Given this list of marker genes H2AC16, KCNJ4, MOB1A, GAS6, CYP3A5, SPRR1B, EPB41L2, IGSF3, ZNF254, STK4, TAF12, MGP, MAGI2, NR4A3, ORC2, PPP1R16B, GNMT, UBTF, RFXAP, NMI, MYH6, C1S, ERICH1 (NCBI Gene Id 441310), CCL18, CPNE1, SOCS1, MYH9, KCTD17, SPINT2, PTPRR, UBB, HLA-DRA, CRH (NCBI Gene Id 1392), TTC39A, UBL3, KNG1, RRP1B, INTS10 (NCBI Gene Id 55174), CCT6B, SNAP25, ADH1B, PAXIP1, CTSC, VOPP1, KMT2A, OBSL1, CKB, PSG11, LAMB3, PRPF3, ZFR2, KRT15, SAPCD1, FN1 (NCBI Gene Id 2335), FNBP1L, TRIB1, PARM1, COL9A3, MYCN, CELF2, TXN, FCER1A, IL1A, RGS9, KIAA0232, ACOT7, HOMER2, PENK, GP1BA, SOSTDC1, CD83, MAOA, ENSA, NRP2, B3GALT5, CCN2, INPP5B, ARVCF, CBS, PBX1, ZSCAN9, PCGF3, ZDHHC18, NCR2, ALOX15, DUSP5, ACTG2, F13A1, PDHA2, RAD50, WFS1, PDCD11, ARSB, PLA2G5, SEMA7A, MMP12 (NCBI Gene Id 4321), HOPX, ATP1A2, COL9A2, CA6, PTPRT, KCNQ1 (NCBI Gene Id 3784), NPHP1, CCL17, MAN1C1, CACNB2, TRAF5, HAGH, IGHE, WNT5A, FAM161A, HLA-DRB4, B4GALNT1, ATAD2B, DIPK1A, CD1B, TNK1, CETP, PRR4, APBA2, RAMP1, TBC1D31, BAAT, PSME2, MRC1, ATP5F1B, AUH, LY75, SAMD4A, FABP4 (fatty acid binding protein 4), P2RY6, LDB3 (LIM domain binding 3), TPM1, RIMS1, TACSTD2, OCM2, CSF2RB, DNASE1L3, PDHX, GALR3, ADAM11, SOX15, IVL, CDK8, MATN2, NDUFV2, HLA-DQA1, DHRS2, RTCA, PLA2G1B, LAMP3, ABL2 (NCBI Gene Id 27), HLA-DPA1, CCR7, KDM4B, OSTF1, MS4A3, TLK2, ETV6, PMP22, HOXC4, PDE4A, HDC, HMGN3, TIMP3, RFTN1, GFI1, PDGFRL, CFP, BCL2L1, ST8SIA4, ADAM19, FCER2, HLA-DPB1, PCOLCE, MARS1, FAM110B, BEX4, CAV3, PALLD, ENOX2, REEP2, CD1C, STUM, FSCN1, IL7R, ALOX15B, TNFAIP2, TUBA1A, RUVBL1, CCL13, ACY1, OSBPL1A, TIPRL, PSMA5, CDH11, PPP2R3A, SETBP1, here is a description of the gene set: Genes up-regulated in comparison of dendritic cells (DC) exposed to T. gondii versus macrophages exposed to T. gondii. species: Homo sapiens Monocyte-derived dendritic cells (DC) and macrophages (MΦ) generated in vitro from the same individual blood donors were exposed to five different pathogens, and gene expression profiles were assessed by microarray analysis. Responses to Mycobacterium tuberculosis and to phylogenetically distinct protozoan (Leishmania major, L. donovani, Toxoplasma gondii) and helminth (Brugia malayi) parasites were examined, each of which produces chronic infections in humans yet vary considerably in the nature of the immune responses they trigger. Human Gene Set: GSE360_DC_VS_MAC_T_GONDII_UP from publication Chaussabel D, Semnani RT, McDowell MA, Sacks D, Sher A, Nutman TB (PMID 12663451)